Given this list of marker genes Zbtb7b, Cd1d1, Vsir, Slc4a2, Twsg1, Ifng, Jak3, Ascl2, Ada, Gimap5, H2-T23, Bcl6, Runx1, Cd44, Adora2a, Zap70, Hfe, Pf4, Jak2, Blm, Hsph1, Cd69, Ptpn22, Ager (advanced glycosylation end product-specific receptor), Lgals9, Arg2, Il4ra, Cbfb, Ap3d1, H2-Ea, Cd24a, Ccr7, Nckap1l, Btla, Zfp35 (zinc finger protein 35), Nfkbiz, Il6, Socs5, Gimap3, Ndfip1, Lilrb4a, Ripk2, Cd28, Mir301, Shh, Prkcz, Cd160, Ccr6, Ccr2, Nlrp3, Rhoa (ras homolog family member A), Zfp683, Ptprc, Il2rg, Sash3, Nkap, Ccl19 (NCBI Gene Id 24047), Cd3e, Ccl20, Il23a, Cd55, Cd80, Socs1, Lgals1, Tnfsf4 (NCBI Gene Id 226545), Il2ra, Hlx, Xcl1, Nfkbid, Pnp, Dapl1, Cd244a, Clec4g, Shb, Cd1d2, Gata3, Mir326, Cd274, Il12b (interleukin 12b), Il27, Prdm1, Itpkb, Smad7, Il12a, Rc3h1, Il18 (interleukin 18), Card11, Cd300a, Ihh, Klhl25, Loxl3, Foxp3, Runx3, Hmgb1, Crtam, Il4, Tgfbr2, Tarm1, Rc3h2, Brd2, Il2, Ap3b1, Cd55b, Malt1, Ep300, Anxa1, Irgm1, Rara, Tnfsf18, Cd83, Cd81, Ankle1, Lilrb4b, Opa1, Tgfb1, Kcnk18, Brd4, Sh3rf1, Gli3, Tnfrsf14, Zc3h12a, Tbx21, Rasal3, Itch, Irf1, Prkcq, Syk, Tyk2, Cblb, Mapk8ip1, here is a description of the gene set: studied in species Mus musculus Any process that modulates the frequency, rate or extent of alpha-beta T cell activation. Mouse Gene Set: GOBP_REGULATION_OF_ALPHA_BETA_T_CELL_ACTIVATION